The following is a description of a gene set: Any process which produces guanosine monophosphate from derivatives of it, without de novo synthesis. studied in species Homo sapiens Human Gene Set: GOBP_GMP_SALVAGE, and this is the list of marker genes: HPRT1, AMPD1, ADK, APRT, ADA